Given this list of marker genes Tmc4, Kcnk4, Tmc3, Tmc7, Tmem63b, Nalf2, Tmc1, Piezo2, Tmem63a, Piezo1, Tmem150c, Tmc2, Tmc5, Kcnk2, Nalf1, Trpv4, Tmc8, Tmc6, here is a description of the gene set: species: Mus musculus Enables the transmembrane transfer of an monoatomic ion by a channel that opens in response to a mechanical stress. Mouse Gene Set: GOMF_MECHANOSENSITIVE_MONOATOMIC_ION_CHANNEL_ACTIVITY